The following is a description of a gene set: Human Gene Set: MIKKELSEN_NPC_HCP_WITH_H3K4ME3_AND_H3K27ME3 from publication Mikkelsen TS, Ku M, Jaffe DB, Issac B, Lieberman E, Giannoukos G, Alvarez P, Brockman W, Kim TK, Koche RP, Lee W, Mendenhall E, O'Donovan A, Presser A, Russ C, Xie X, Meissner A, Wernig M, Jaenisch R, Nusbaum C, Lander ES, Bernstein BE (PMID 17603471) We report the application of single-molecule-based sequencing technology for high-throughput profiling of histone modifications in mammalian cells. By obtaining over four billion bases of sequence from chromatin immunoprecipitated DNA, we generated genome-wide chromatin-state maps of mouse embryonic stem cells, neural progenitor cells and embryonic fibroblasts. We find that lysine 4 and lysine 27 trimethylation effectively discriminates genes that are expressed, poised for expression, or stably repressed, and therefore reflect cell state and lineage potential. Lysine 36 trimethylation marks primary coding and non-coding transcripts, facilitating gene annotation. Trimethylation of lysine 9 and lysine 20 is detected at satellite, telomeric and active long-terminal repeats, and can spread into proximal unique sequences. Lysine 4 and lysine 9 trimethylation marks imprinting control regions. Finally, we show that chromatin state can be read in an allele-specific manner by using single nucleotide polymorphisms. This study provides a framework for the application of comprehensive chromatin profiling towards characterization of diverse mammalian cell populations. studied in species Mus musculus Genes with high-CpG-density promoters (HCP) bearing the bivalent histone H3 trimethylation mark at K4 and K27 (H3K4me3 and H3K27me3) in neural progenitor cells (NPC)., and this is the list of marker genes: KCNJ4, MNX1, HMX2, KCNH3, EOMES, ITGA3, NPPC, ANKRD33B, NOG, SMAD6, MFSD4A, ELFN1, FOXF1, NRARP, CPEB1, MYRIP, FGF19, HOXD13, FOXC2, KCNK12, TSPAN18, FRMD5, NDRG1, PCSK2, GATA6, BMF, P4HA2, HOXC5 (NCBI Gene Id 3222), CDK5R2, RET (NCBI Gene Id 5979), GPAT3, RASSF5, AMER3, PAQR9, COL27A1, SLC35F2, FOXQ1, PLTP, NEUROG2, PRMT8, INA, SH3RF3, NEFL, KCNA1, HOXC4, PRDM6, GCHFR, CDS1, BIK, PLXNA4, NTNG1, TENM4, GAD1, LAMA1, VSTM2B, NGFR, BICDL1, SNTB1, SYNM, FOXB1, A4GALT, EMB, SLC35D3, DLL4 (NCBI Gene Id 54567), TGFB1, GPR45, RAB20, ACAN, OAF, SFI1, BMP8A, CDHR1, SHH, KCNC4, KDELR3, CDH22, FGF5, ADAMTS2 (NCBI Gene Id 9509), AFF3, HRK, KIF5C, FGF11, MSX2, WNT11 (Wnt family member 11), MMP24, GDNF, KLHDC8A, ADORA1, STK32C, HOXD1, NMNAT2, SIX2, NEFM, TMTC4, JPH1, PTGER3, HMX1, PTGER4, OCLN, SLC24A4, STX3, SLC24A2, MAP3K9, ATP7B, GJA3, ADORA2B, SOX1, CRH, PTPN5, SATB1, BAIAP2L1, GNG8, XKR5, KNDC1, PLEKHG3, TUBA4A, TMEM181, RASGRF1, CDH11, ABLIM2, WNT9A, FLI1 (NCBI Gene Id 2313), GPR88, SLC40A1, TFAP2A, DISP3, FAM78A, ADAMTS8, SLC26A4, ERBB3, AK5, ESRRB, SPIRE2, ST8SIA2, GALNT14, BHLHE22, CXCL12, TEAD4, FBXO43, CXCR4, CLDN23, RELN, RSPO2, EGR4, CHST8, COCH, CSMD1, IGF2BP2, ZNF296, ICA1L, CELSR3, ATOH1, VGF, ASCL2, SMOC2, AP3B2, GABRA4, NEUROG1, PTPRU (NCBI Gene Id 10076), ADRA2B (adrenoceptor alpha 2B), ARG2, RGS6, FOXF2, GNAL, BMI1, CCNO, PTH2, PTGFRN, PODN, ADRB3, MAPK8IP2, CBLN1, KCNK1, TRNP1, TACR1, TUB, GCH1, CASZ1, CDKN1A, NXPH3, KCNA3, SEMA7A, NXPH4, CAMKK1, FLT1, PLAG1, RGS9BP, PCDH8, WNT6, CHRNA5, KIAA1549L, WNK2, FOXD4, SLC6A15, INSM2, UNC5A, KCNMA1, FGF9, SLC30A10, RASGEF1B, GPC5, PTPRN2, PSMB9, GPRC5C, CCDC85A, EGFLAM, HS3ST3A1, C2CD4B, AHNAK, EFCC1